The following is a description of a gene set: Supernumerary digits located at the radial side of the hand. Polydactyly (supernumerary digits) involving the thumb occurs in many distinct forms of high variability and severity. Ranging from fleshy nubbins over varying degrees of partial duplication/splitting to completely duplicated or even triplicated thumbs or preaxial (on the radial side of the hand) supernumerary digits. Preaxial hand polydactyly Human Gene Set: HP_PREAXIAL_HAND_POLYDACTYLY species: Homo sapiens, and this is the list of marker genes: KIF7, TCTN3, FGFRL1, HEATR3, NEK1, CHN1, TCTN1, SALL1, RPGRIP1, TMEM216, ZNF699, HYLS1, CTBP1, RAB34, FANCD2, HEPACAM, TMEM231 (NCBI Gene Id 79583), EXTL3, WDR35, PHF8, TMEM237, LETM1, MKS1, CC2D2A, DYNC2H1, HOXD13, PTEN, LMBR1, IFT80, CEP290, CPLX1, CPLANE1, B9D2, TCTN2, SALL4, DACT1, FGFR2, TFAP2A, GLI1, PIGG, DYNC2I2, NSD2, GJA1, MAFB, CDC45, SMO, DYNC2I1, RPGRIP1L, TMEM107, CSPP1, GLI3, PUF60, NELFA, TXNDC15, B9D1, EFTUD2, TMEM67, OFD1, BHLHA9, ZSWIM6